The following is a description of a gene set: Pathway Definition from KEGG: Cohesin -> ATRX == Cohesin == NIPBL+MAU2 -> DDX11 == Cohesin+NIPBL+MAU2 studied in species Homo sapiens Human Gene Set: KEGG_MEDICUS_REFERENCE_COHESIN_LOADING Cohesin loading. Pathway ID: N01482. Pathway type: Reference. Pathway class: nt06512 Chromosome cohesion and segregation., and this is the list of marker genes: MAU2, STAG1, SMC3, NIPBL, ATRX, DDX11, SMC1A, RAD21, STAG2